The following is a description of a gene set: Cell death resulting from activation of endogenous cellular processes and occurring as a result of a reactive oxygen species stimulus. Reactive oxygen species include singlet oxygen, superoxide, and oxygen free radicals. Human Gene Set: GOBP_PROGRAMMED_CELL_DEATH_IN_RESPONSE_TO_REACTIVE_OXYGEN_SPECIES studied in species Homo sapiens, and this is the list of marker genes: PAWR, PINK1, ENDOG, DDR2, RACK1, MIR133A1, MIR34A, HGF, PDCD10, FOXO3, MIRLET7B, TRAP1, MIR21, MET, MIR17, STK25, MIR92A1, PARK7, MAP2K4, FOXP1 (NCBI Gene Id 87246), AKT1, PJVK